The following is a description of a gene set: Human Gene Set: GSE46606_IRF4_KO_VS_WT_CD40L_IL2_IL5_3DAY_STIMULATED_BCELL_UP Genes up-regulated in CD40L and IL-2 IL-4 IL-5 stimulated at day 3 B cell IRF4-KO versus CD40L and IL-2 IL-4 IL-5 stimulated at day 3 B cell wildtype. Temporal analysis of B cell activation in vitro using CD40L and IL-2/4/5 cytokines in wild type Irf4+/+ B cells or in mutant Irf4-/- B cells harboring a tet-inducible allele of Irf4. IRF4 expression was restored, or not, in the Irf4-/- background by culturing in the presence of low or high concentrations of doxycycline. The results provide insight in the role of IRF4 expression levels in coordinating different programs of B cell differentiation. from publication Ochiai K, Maienschein-Cline M, Simonetti G, Chen J, Rosenthal R, Brink R, Chong AS, Klein U, Dinner AR, Singh H, Sciammas R (PMID 23684984) species: Homo sapiens, and this is the list of marker genes: PGK2, TRAF5, MCOLN2, SPINT1, C3orf38, CYP27B1, FAM110B, GOLGA8B, SLAMF9, PITRM1-AS1, TLE1, FAM162A (NCBI Gene Id 26355), MMP12, SCARB1, PDILT, IL2RA, DENND5A, EGLN3, CCL22, PRODH, PRELP, GAS6, HMGB3, ABCG1, ACVRL1, NR4A3, GALNT18, SEL1L3, SINHCAF, TSPAN33, ZC3HAV1L, IL21R, MREG, RRP1B, MAOA, C17orf58, DNAH14, PHLDB3, TFRC, ARL5C, CD86, SLC20A1, PLA2G6, COLEC12, QSOX1, ALDH1A2, BDH2, FGF22, ALOX15, AURKA, ASAP2, KCNK13, FOXK1, NCOR2, ACOX3 (acyl-CoA oxidase 3, pristanoyl), PFKP, NCK2, RAB33A, RASAL2, C3orf18, GSE1, CISH, ITPRIPL2, SLC1A2, RUFY3, SOX4, VPS13A, AUH, MAP3K21, PITRM1, BCL7A, RGS1, CDCA5, LAMP3, MYL5, SYNGR2, IFNGR2, HSD11B1, FCER2, LMBR1L, CTNNAL1, CD274, STK26, TRADD, VEGFA, ANGPTL1, AZIN2, SQLE, AK3 (NCBI Gene Id 50808), EPOP, ABCA5, RIPK2, FAS, DARS1, TRIP10, CCL17, MPZL1, DHRS13, HOPX, TRPV1, ZNF141, IGF1R, STARD4, PXYLP1, MRPS6, CD200, FOXQ1, FBP1, LINC03025, SYT17, FADS2, NDUFV2, SCD, PKD2, SC5D, P4HA2, MTCL1, DHCR24, SLAMF1, SMAD7, GADD45A, SPRED2, BHLHE40, GOLGA8A, PTPN1, CD40, DCUN1D3, GANC, HEXIM1, MCL1, EDEM1, FASN, TGFA, TRABD2A, TGM2, LDHA, MAP3K13, EHF, TRAF1, CCL13, CCL18, CLEC4G, SOCS1, BMAL2, KCTD3, NIPA1, TPD52, THBS3, WNT5A, LY75, SUSD1, ADAMTS15, ZNF512B, ALAS1, RHOF, ERI1, DENND2B, CCDC6, NFIL3, MAP3K4, TBRG4, A2M, ALOX15B, RAMP1, CCL23 (C-C motif chemokine ligand 23), SLC49A4, FABP3, UGP2, MSMO1, SLC5A3, NRBP2, ACOT7, XXYLT1, MTFP1, CD226, FADS1, DUSP5, HSD17B12, AFDN, EFL1, SEZ6L, SPINT2, JAG1, MAST4, GRAMD1A, GPR146, CRLF2, PGM1, MMD, LITAF, APEX2, BATF3, DHRS11 (NCBI Gene Id 79154), TUBA1A, SLC25A36, BCL2L11